Given this list of marker genes C1orf53, YY1, LPCAT2, GAS2, KBTBD2, DCX, NUDCD1, GYG1, BBS7, ASB4, NCAPG2, FNBP4, RP2, STK3, SORCS1, SCLT1, ZBTB20, PHF6, GOLM1 (golgi membrane protein 1), ZNF566, RGS9BP, LPP, BPNT1, PTPN3, DNAJB9, ELAC1, IKBIP, OST4, CATSPERE, MB21D2, CTSC, DENND1B, MLF1, KCMF1, HLF, PUM1, EEIG2, APOBEC4, PDE11A (NCBI Gene Id 50940), CHD8, THAP10, ZNF432 (NCBI Gene Id 9668), TMEM255A, PRKD3, XKR9, CNTN1, FA2H, WNK3, KANK2, KDM7A, PPP1R11, FBXO33, DYRK2, GSPT1, RGS7BP, CABYR, AIG1, ENPP2, PIGM, TCF12, GPR85, HAPSTR1, CNGB1, PHAF1, PMP2, ELAVL1 (NCBI Gene Id 1994), CNKSR2, TOX, FAM171A1, CLTA, ETV1, BHLHE22, AMZ1, AHCYL1, SLC4A10, ENPEP, ATXN1L, CDH8, SETBP1, UHMK1, ULK2, GUCY1A2, SLC9A9, PRR11, MEX3A, TESMIN, SIMC1, PLPP6, MTRF1L, MAD2L1BP, G6PC2, SLC25A31, RBBP4, EFHC2, EIF3A, GAS1, MECOM, here is a description of the gene set: Human Gene Set: MIR3159 species: Homo sapiens Genes predicted to be targets of miRBase v22 microRNA hsa-miR-3159 in miRDB v6.0 with MirTarget v4 prediction scores > 80 (high confidence targets). from publication Chen Y, Wang X (PMID 31504780)